Given this list of marker genes ATP5F1A, LAMA4, PARD6A, MRPS24, LANCL1, NANP, COL4A5, HMGB2, PEPD, VAMP4, ATP5PF, NEPRO, PEX2, PDLIM2, ARRB1, GSTO1, NDUFB2, HCFC1R1, TNNT1, PPIL4, UPB1, PLD1, SNX14, SMIM12, CATSPERG, CCNG1, TMEM51, PTPRS, ATP5F1E, CPT2, HPCAL1, SSB, PLA2G15, SSBP4, SFXN3, PTS, HEPACAM2, STK11, ELOVL6, MRPL51, SMPDL3A, MUL1, TFB2M, SLC25A45, FKBP11, CD81, NDUFA13, MRPL42, MRPL47, KIF1C, BDNF, PLPP2, RPL28, RNPC3, CORO1A, DDX41, DAD1, MCEE, CRADD, NELL2, TMEM14C, NKX2-4, HMGCS2, TNFRSF13B, SIPA1, SLC25A39, CNIH4, SPC25, MGAT2, ANXA3, LTC4S, HADHB, FAM193B, CCNI, NIT1, IDS, RNASE4 (NCBI Gene Id 6038), EIF3L, SKA1, STARD4, LIN28A, ANKRD10, CCDC115, MCM7, MOS, WIPI1, IFI30, SOBP, SLC37A1, POLG, MRPL2, PARP16, HTATIP2, SLC37A3, SUPT16H, APRT, RPS5, AKR7A2, CREBRF, GOLM1, PABPC4, CYP4F3, TBX2, SC5D, S100A1, PTPN18, MMP19, TTYH2, ZBTB20, ARHGAP45, RBBP7, PDYN, TF, CPPED1, GNG10, PTK6, FRRS1, RANBP10, SLC41A3, GLUD1, HNRNPLL, TCTE1, SLC40A1, C1QBP, ABCA2, CLYBL, WWOX, ARHGAP17, CD74, HOMER1, SKI, XPR1, MBIP, RGS10, TMUB2, SAAL1, CDC20, BUB1, PHKA2, EEF1B2, GNE, ABHD15, ZIC2, MIDN, ABCD2, ATP5F1B, FTCD, ANKH, ANGPTL6, GAB3, ATG9B, PDK3, EEF1D, FUCA2, NDUFA2 (NCBI Gene Id 4695), YPEL1, TNRC6A, CACNA1A, MYL12B, MRPS26, SLC25A4, PALD1, SNX15, MKNK2, CDON, SPG21, PGM1, MINDY1, ABCD1 (NCBI Gene Id 215), ADAMTS10, NDUFAB1, MMP1, EHHADH (NCBI Gene Id 1962), CENPF, SMPD2, KIF20A, CDK2, CXCR3, GASK1B, KXD1, ZNF124, CENPV, ZNF18, HACL1, PLXDC1, CTSA, RNFT1, PIGQ, CASP6, RPL41, RPL6, RERE, BAIAP2, ASF1B, CPSF4, ADIPOQ, QRSL1, TRAPPC14, FMC1, APOC2, here is a description of the gene set: from publication Amit I, Garber M, Chevrier N, Leite AP, Donner Y, Eisenhaure T, Guttman M, Grenier JK, Li W, Zuk O, Schubert LA, Birditt B, Shay T, Goren A, Zhang X, Smith Z, Deering R, McDonald RC, Cabili M, Bernstein BE, Rinn JL, Meissner A, Root DE, Hacohen N, Regev A (PMID 19729616) Human Gene Set: GSE17721_CTRL_VS_GARDIQUIMOD_12H_BMDC_UP mouse primary BMDCs were stimulated with tlr ligands and gene expression changes were profiled on Affymetrix arrays Genes up-regulated in comparison of control dendritic cells (DC) at 12 h versus those stimulated with Gardiquimod (TLR7 agonist) at 12 h. species: Homo sapiens